The following is a description of a gene set: studied in species Homo sapiens Human Gene Set: GOBP_REGULATION_OF_POSTSYNAPTIC_DENSITY_ORGANIZATION Any process that modulates the frequency, rate or extent of postsynaptic density organization., and this is the list of marker genes: LRFN4, LRRTM2, CFL1, PTPRS, PRICKLE1 (prickle planar cell polarity protein 1), GRID2, ABI3, IL1RAP, PTK2B, CBLN1, LRRC4B, FGFR1, PTPRD, ZMYND8, CRIPT, SLC30A1, LATS1, CDH2, LRFN1, CASKIN1, LILRB2